The following is a description of a gene set: p38 MAPK signaling studied in species Homo sapiens Human Gene Set: WP_P38_MAPK_SIGNALING, and this is the list of marker genes: RIPK1, SMIM40, TGFB2, HMGN1, ATF2, MEF2D, HSPB1, MAP3K9, SHC1, CDC42, RAC1, MAX, CREB1, STAT1, HRAS, MAP3K1, TRADD, MAPKAPK5, MAP3K5, RPS6KA5, RASGRF1, ELK1, MAP3K7, MAPKAPK2, MYC (NCBI Gene Id 731404), MAP2K4, TRAF2, TGFBR1, MAPK14, DAXX, PLA2G4A, MKNK1, MAP2K6, GRB2, DDIT3